The following is a description of a gene set: species: Mus musculus Mouse Gene Set: ZFP467_TARGET_GENES from publication Yevshin I, Sharipov R, Kolmykov S, Kondrakhin Y, Kolpakov F (PMID 30445619), and this is the list of marker genes: Chd3, H1f2, Slc1a5, Elfn2, Lpgat1, Elp2, Fbxo15, Rfx2, Nol4, Babam2, Smg7, Top6bl, Gm12694, Hcn4, Chst12 (carbohydrate sulfotransferase 12), Pipox, Otp, Lrsam1, Gsk3a, Ubl3, Cnot6, Adhfe1, Ap1g1, Mettl17, Gm2479, Gm15743, Zc3h6 (zinc finger CCCH type containing 6), Srsf7, Cdk19, Gm8495, Rnf115, Hoxa3, Pheta2, 4930589O11Rik, Cdh22, 4930583K01Rik, Trerf1, Lpp, Gm9929, Cdk8, Gm28042 (predicted gene, 28042), Phf14, Car2, Pfn2, Yap1, Bend4, Cdh1, Zmynd8, Nova1, Ppp1r1b, Sae1, Zdhhc18, Gm10524, Neat1, Josd2, Pcbp4, Dock6, Ppp2ca, Btg2, Grik4, Gstcd, Ppp1r14b, Mir7666, Slc39a6 (solute carrier family 39 (metal ion transporter), member 6), Slc38a1, Hvcn1, Snrpb2, Zic2, Atg16l1, Tada2a, Nthl1, Klhl2, Gm28874, Cox10, 5031434O11Rik, Dusp18, Hps4, Reps2, Slc24a3, Ppargc1b, Junb, Nog, Phldb2, Calr, Stk38, Gpr158, Kmt5c, Uck2, Dusp6, Cinp, Comp, Pet117 (PET117 homolog, NCBI Gene Id 100048644), Pxn, Acaca, Lhx1os, Mir3960, 6430573P05Rik, Mllt10, Tmem242, Naa30, Enc1, Mgst3, Mycbp2, Sema7a, Noc2l, Abi2, Slc25a22, Klhdc8b, Arid1b, Aebp2, Zfas1, Polrmt (polymerase (RNA) mitochondrial (DNA directed)), Gtdc1, Pank2 (pantothenate kinase 2), 1700034P13Rik, Vps52, Ctnnb1, Tgfb1, Rdh10, Gm34086, Arhgap26, Wdr12, Nrdc, Rragc, Gm13999, Trib3, Bcl11b, 1500002C15Rik, Ankrd24, Vps37b, Kmt5b, Tob2, Gkap1, Zmiz1, Fam219a, Tbxa2r, Trp53cor1, Boll, Dedd, Rnf182, Zswim4, Hnrnpl, Cdipt, Gnb2, Lmbrd2, Wwc2, 1700086P04Rik, Lag3, Smurf1, Usp9x, Mctp1, Gm13610, A730035I17Rik, Zfp207, Wnt9b, Mir291a, Ptpn4, Bmi1, Pid1 (phosphotyrosine interaction domain containing 1), Ppp1cb, Rbks, Sltm, Svop, Adamtsl4, Twf2, Snord3a, Nhsl2, Itpr1, Srpk2, Olfml2b, Gm15853, Dlg5, Fbxw11, Mark1, Lrba, Mitd1, Zfpm1, Casp3, Crebl2 (NCBI Gene Id 57903), Lyrm1, 2810032G03Rik, Grm4, Rsf1, Dok5, Tmem185b, Slc18a3, Smarcc2, Dbt, Wnt11, 1700029J03Rik, Tecpr2, Stap2, Sertad2, Hmgb1, Smg1, Srrm2, Homez, Pcnx1, Cltc, Ncoa3, Misp, Orai1, Kat6b, Tjp2, 2610035F20Rik, Pomt1, Ash2l, Wtap, Rims4, Slc6a6, Jmjd7, Mier1, Usf2, Zbtb7a (zinc finger and BTB domain containing 7a), Nedd4, Fry, Rhd, Fahd2a, Serping1, Gaa, Sh3rf1, Gm25878, Plcb4, C1qtnf4, Hycc2, Cpm, Sfxn4, Ubqln4, Kif23, Ints12, C330002G04Rik, Cyp1b1, Slc25a20, Ganab, Mir290a (NCBI Gene Id 100049710), Rbpj, Mir6236, Lmo1, Foxd2os, Cracr2b, Nbeal2, Arhgef16, Rex1bd, Lrfn5, Dpep3, Usp49, Gm5447, Zc3h4, Foxd2, Coq10a, Gm26756, Prr5, Tnfaip2, Laptm5, Dhodh, Nsd1, Smim14, Rasal2, Slc39a3, Mpnd, Rsrc1, 1700058P15Rik, Stk38l, Rflna, Crtc1, Ogg1, Spns1, Ak4, Hipk3 (homeodomain interacting protein kinase 3), Fam3c, Commd1, Nedd4l, Primpol, Ube2ql1, Adgrl1, Cxxc4, Fgf20, 2210411M09Rik, Capza1, Eomes, Dok3, Tnfaip1, Gm8066, Btf3l4, Plpp3, Mrpl48, Samd1, Flnc, Lamtor2, Snora7a, Gpr153, Gm2018, Ppp3ca (protein phosphatase 3, catalytic subunit, alpha isoform), Neo1, Pacsin3, Crabp1, Fam222a, Gm15165, Ctnnd2, Slmap, Tmem240, Zfp423, Mbtps2, Gm14964, Arid3c, Ctbp2, Anapc15, Ankrd13a, Vcl, Cdc14a, Rbmxl2, Dnaaf10, Pan3, Cab39, Foxc1, Rps6ka5, Rhbdf1, Dnajb14, Runx2, Tsc2, Ppig, Irf8, Epo, Rapgef1, Ttc39d (NCBI Gene Id 67737), Chd9, Nrxn3, Ccdc71, Sh3bp5, Syt1, Kmt2d, 2410002F23Rik, Parp3, Shc4, Rpl12 (ribosomal protein L12), Faf1, Polm, Spp1, Ppp2r5c, Mir1894, Akap11, Ino80d, Emp3, Irx2, Plekha7, Scmh1, Gtf2a1, Ptger1, Gnmt, Plcl2, Nudt2, Ntn4, Dusp8 (dual specificity phosphatase 8), Vwa8, Cux1, Polr3c, Atl1, Lhx2, Pde4a, Appbp2os, Mcf2l, Atrx, Patl1, Sec22c, Whrn, 5330413P13Rik, Yipf1, Spc24, Nrip1, Gm15351, Pcdhga8, Slc1a1, 9430091E24Rik, Rimkla, Rpl7, Map2k2, Slx1b, Sec23a, Alpl, Ctcf, Garnl3, Eif4e (eukaryotic translation initiation factor 4E), Lfng, Rcbtb1, Rrp9, Efcc1, Mir2861, Mgat5b, Chi3l1, Akt1, Mrpl15, Bola2, Tgfb2, Slc13a3, Kat14, Gck, D5Ertd579e, Cdiptos, Gfod1, Txndc12, Atpaf1, Map4k4, Spdef, Rnaseh2c, Dact3, Rnf220, Nfat5, Gm10575, Dnai4, Gm26247, Rcor1, Mir9-1, Tfdp1 (transcription factor Dp 1), Smtn (NCBI Gene Id 29856), Abcd4, Hpca (NCBI Gene Id 15444), Eps15, Hexim2, Hectd3, Rapgef2, Kif24, Gamt, Ttc7, Lyrm4, Gtf3c6, Myo5a, Ndufa4, Dcaf10, Tmem59l, Jak2, Rpl32, Pom121, Fam168a, Efcab14, Dnai1, Nhlrc1, Inpp5f, Cplx1, Gm9103, Gm2990, Disp3, Ubald1, Ppp1r10, Snord118, H2bc3, Slc18b1, Shox2, Porcn, Depdc1b, Bbs5, Fgfr2, 9430015G10Rik, Atrnl1, Fos, Gm2822, Napb, Med17 (mediator complex subunit 17), Katnbl1, Mir7226, Ttc14, Slc38a6, Anln, Zfp236, Grb7, Mrps18b, Uts2, Trmt5, Fndc5, Phtf1, Nabp1 (nucleic acid binding protein 1), Srrd, Map4k5, C430039J16Rik, Slc44a1, Maml3, Rhof, Rnf19b, Prkar2b, Ppp1r18os, Tapt1, Pla2g2e, Gm42632, Fars2, Atp2a3, Ccng2, Cerkl (ceramide kinase-like), Rbm15b, Ldlrad4, Atp11a, Gm16675, Ift20, Csnk2a2, Ptprf, Utp3, Rc3h2, 2810025M15Rik, Set, Gadd45g, Prss16, Ube2i, Pno1, Adamtsl5, Unc93b1, Fgfr3, H2ac5-ps, Rai2, Irf2, Ube2k, Atf6, Car7, Eef1a1, Hapln4, Pde10a, Tspan4, Angel1, Frmd8os, 9330104G04Rik (NCBI Gene Id 320950), Fam78a, Eapp, Ndufb3, Unc119, Gm13025, Bcl2, Skp2 (NCBI Gene Id 75034), Phospho1, Atp1a1, Src, Syt7, Uba7, Igf2bp2, Dyrk1b, Xylt1, Zmat3, Tpp2, Mir1249, Eef2k, Mysm1, Aplp1, Hps3, Ino80dos, Cdk9, Mir292, Znfx1, Rps18, Rai14, Bmp7 (NCBI Gene Id 12162), Znrf2, Foxo1, Bbc3, Nubp1, Lrp6 (low density lipoprotein receptor-related protein 6), Zfp746, Polr2l, Gm2453, Tsc22d1, Memo1, Satb1, Gm20511, Acot7, 4921536K21Rik, Acot8, Lrrc8b, Arl15, Zfp609, Dcun1d3, Ankrd39, Lmnb1, Aftph